The following is a description of a gene set: Mouse Gene Set: GOBP_NEGATIVE_REGULATION_OF_SMOOTH_MUSCLE_CELL_CHEMOTAXIS Any process that stops, prevents, or reduces the frequency, rate, or extent of smooth muscle cell chemotaxis. studied in species Mus musculus, and this is the list of marker genes: Aif1, Gstp1, Slit2, Gstp2, Coro1b